Given this list of marker genes Gpc2, Ids, Naglu, Gpc3, Sdc3, Sgsh, Hpse2, Sdc1, here is a description of the gene set: part of: Heparan sulfate/heparin (HS-GAG) metabolism Reactome Pathway: HS-GAG degradation species: Mus musculus This event has been computationally inferred from an event that has been demonstrated in another species.<p>The inference is based on the homology mapping from PANTHER. Briefly, reactions for which all involved PhysicalEntities (in input, output and catalyst) have a mapped orthologue/paralogue (for complexes at least 75% of components must have a mapping) are inferred to the other species. electronically inferred by orthology from the curated human pathway